Given this list of marker genes GADD45G, MAP2K6, PER1, GADD45A, MAP2K3, OPRK1 (opioid receptor kappa 1), PRMT1, MAPKAPK2, KCNJ8, DSC2, MAP3K6 (NCBI Gene Id 9064), MFHAS1, DUSP10, STK39, LEP, GDF6, MIR181A2, TREM2, IL1B, AGER, SASH1, DUSP1, ULK4, BMP2, CYLD, PJA2, DLG1, DSG3, HAND2, MAP3K20 (NCBI Gene Id 51784), MAPK11, HGF, ZC3H12A, LGALS9, MAP3K15, MAPK14, GADD45B (NCBI Gene Id 4616), MAP1LC3A, ATF2, PHLPP1, CAV3, MAP3K7, RELL2, SPHK1, EZR, MAP3K4, SPI1, BMP4, MIR181B1, DAB2IP, BECN1, PTPN22, MIR181D, MAP3K3, MIR20A, ZFP36L1, MINK1, MAP3K5, RELL1, ZFP36, here is a description of the gene set: studied in species Homo sapiens A MAPK cascade containing at least the p38MAPK (MAPK14) MAP kinase, or Hog1 in yeast. It starts with the activation of a MAP3K, and the consecutive activation of a MPK2K and of p38MAPK. The cascade can also contain an additional tier: the upstream MAP4K. The kinases in each tier phosphorylate and activate the kinases in the downstream tier. The p38MAPK cascade is activated by stress signals, including hyperosmolarity, as well as by G protein-coupled receptors, growth factors, and cytokines, and results in cellular responses such as cell proliferation, cell differentiation, apoptosis and inflammation. Human Gene Set: GOBP_P38MAPK_CASCADE